The following is a description of a gene set: Mouse Gene Set: MIR_694 studied in species Mus musculus from publication Chen Y, Wang X (PMID 31504780) Genes predicted to be targets of miRBase v22 microRNA mmu_miR_694 in miRDB v6.0 with MirTarget v4 prediction scores > 80 (high confidence targets)., and this is the list of marker genes: St18, Spice1, Nek4, Slc28a2b, Tmem67, Kif1b, Nwd2, Pgm2l1, Sh2d1a, Pik3c2g, Dnmt3b, Ect2, Clic5, Cd2ap, Rhobtb3, B3galt2 (NCBI Gene Id 26878), Ttpa, Gria2, Zdhhc21, Chp1, Vps37a, B230219D22Rik, Gprc5b, Fmr1, Htr5a, Kdm7a, Tox, Ncoa7, Ap1s2, Cpvl, Man2a1, Wnt3a, Tmem39a, Arih2, Mrgprb1, Pigp, Pik3c2a, Gnpda1, Thsd7a, Grik2, Uba3, Uchl4, Cpeb3, Epha4, Nsd3, Slc31a1, Tmcc2, Naaladl2, Phf6, Dnajb11 (DnaJ heat shock protein family (Hsp40) member B11), Atrx, Spty2d1, Dach2 (NCBI Gene Id 93837), Rwdd4a, Ccdc82, Hamp2, Csk, Golm2, Bbx, Pkp2, Slc30a7, Ints8, Smurf2, Pcdhb21, Nap1l5, Ino80d, Kcnmb1, Slain1, Fndc3c1, Washc4, Bdp1, Ap1g1, Eml6, Msi2, Rsbn1, Ppp1r27, Rbm47, Mxi1, Eefsec, Nfyb, Nrg2, Rabep2, Hook3, Srsf11, Jade3, Ehf, Nipal1, Clic4, Fgfr2, Srsf6, Mospd2, Mfap3l, Rora, Lpar4, Slc28a2, Prdm1, Btbd1, Cd46, Zbtb10, Lsm14a, Pcdh10, Cul3, Hacd2, Zfp462, Clmn, Phf3, Wasl, Prr14l, Taok1, Dnm3, Tbc1d12, Ppp4r2, Hoxb2, Cnbp (cellular nucleic acid binding protein), Paxbp1 (PAX3 and PAX7 binding protein 1), Fmn2, Ano1, Sirpb1b, Adk, Ammecr1, Ccdc141, Saxo2, Kpna4, Bicd1, Hipk1, Pibf1, Ngf, Carmil1, Ska1, Peg10 (NCBI Gene Id 30899), Ggct, Zfp518a, Mfsd14b (major facilitator superfamily domain containing 14B), Aco1, Pgm2, Opcml, Tmx4, Slc10a7, Slc35g1, Ehbp1, Arsk, Gnpnat1, Ano5, Ccdc62, Lhx4, Tmem200a, Rab21, Cpeb2, Itprid2, Cacna2d2, Rchy1, Bmpr2, Gucy2f, Etaa1, Kif18a, Calr3, Nup160, Atf6, R3hdm1, Mat2a, Kcnj12, Cnst, Sowahc, Ugt2a3, Pabpc5, N4bp2l2, Bin3, Rap1b, Akap5, Phactr3, Slitrk2, Gabrg1, Chic2, Miga1, Edil3, Trhde, Cxadr, Tnrc6b, Pxn, Tmed7, Dclk1, Elavl1, Cdh6, Dcun1d3, Afg3l2, Epha7, Mtx3, Galnt18, Xpo7, Elovl6, Ltv1, Rev1, Fam81a, Kpnb1, Osbpl6, Chmp1b, Zfp871, Clec1a, Dazl, Tead1, Zfp711, Plcl1, Osr2, Nsg2, Hamp, Hecw2, Wac, Erp44, 2610528J11Rik, Alg5, Mdfic, Fzd3, Pakap, Cxxc4, Rprd1a, Il7, Rimklb, Asxl3, Cldn34b2, Psip1, Plagl2, Cyp2c38, Yap1, Gadd45a, Txnip, Flii, Apool, Mbtps1, Kcnh5, Socs4, Zkscan2, Cyp39a1, Leprotl1, Setd5, A830018L16Rik, Ppp1r2, Ptchd4, Stau1, Pcdh20, Ptger4, Lin7c, Bpnt2, Ube2a, Alkal2, Tmem168, Braf, Klf12, Cggbp1, Trub1, Akr1c14, Clock, Smad2, Sp3, Asxl2, Nexmif, Laptm4a, Pafah1b2, Slc1a3, Rerg, Mindy2, Ddx3y, Slc7a11, Becn1, Slc30a4 (solute carrier family 30 (zinc transporter), member 4), Sgms1, Phlda2, Tnfrsf21 (NCBI Gene Id 98092), Tmem263, Negr1, Ces5a, Crispld1, Bag2, Lca5, Map3k1, Gosr1, Pou3f3, Dsc1, Prrg1, Ubxn2a, Kansl1, Tlr8, Mospd1, Abce1, Zmat3, Tesk2, Pcsk6, Dcx, Lpar6, Fut9, Cdc73, Zdhhc24, Acadsb, Lnpk, Asph, Foxk1, Zfp781a, Ptprb, Pate12, Cdk12 (cyclin dependent kinase 12), Marchf5, Tet1, Steap4, Ing5, Ano3, Tmtc3, Elavl2, Sanbr, Paqr8, Oxsr1, Dnmt3a, Gcc2, Esrrg, Apbb2, Capn7, Gm15881, Kpna3, Lamtor2, Chl1, Bnc1, Mgat4a, Glis3, Zbtb41, Radx, Arhgap6, Slc7a14, Txlng, Tll1, Pgr15l, Dmc1, Rapgef6, Unc5c, Aff4, Crybg1, Lhx9, Kmt5b, Nme7, Enox1, Dner, Shtn1, N4bp2, Ppp1r1c, Pou3f4, Zfp934, Zfp830, Dars1, Mtpap, Dpp8, Ccdc117, Efcab5, Appl1, Chrdl1 (chordin-like 1), Dennd6a, Slc8a1, Nhsl1, Sec24a, Rad23b (NCBI Gene Id 78352), Pyurf, Ypel2, Spred1, Galnt13, Pclaf, Tph2, Rasef, Ces2g, Ebf1, Csnk1g3, Arih1, Sertad4, Slc39a8, Bptf, Hdx, Dzip3, Zmynd11, Pde10a, Son, Ttc14, Thoc2 (THO complex 2), Tmem59, Rbm25, Zfp704, Rheb, Tubd1, Tubgcp3, Pgbd5, Prkd1, Pcnx1, Snrnp48, Pfkfb2, Whrn, Kdm8, Uri1, Phf14 (NCBI Gene Id 76289), Stap1, Mtmr11, Kank1, Hsd17b7, Lrch1, Fst, Fcsk, Mef2c, Vcan, Rnf138, Rbak, Ptprg, Plscr1, Map2, Pld6, Glce, Nufip2, Mphosph9, Picalm, Scn8a, Skida1, Vcpip1, Vstm2a, Ppp2r5e, Esco1, Abi3bp, Pnisr, Klhl23, Eddm13, Exo1, F2r, Il1rap, Bdnf, Cldn34b4, Sox2, Grm5, Hsd17b4, Xk, Rel, Uchl3, Ptchd1, Insm1, Suox, Ankmy2, Pou2af1, Zc3h6, Slc38a2, Ccser1, Zbtb44, Cldn1, Pfdn4, Pianp, Cldn34b1, Larp4, Pitpnb, Cltc, Uba2, Kcnj13 (NCBI Gene Id 100045137), Eml5, Chic1, Mgat1, Nphp1, Ccn4, Gab2, Ranbp3l, Smg1, Nab1, Zeb2, Lman2, Cbx5, Runx2, Arl6, Fat3, Vangl2, Kdr (kinase insert domain protein receptor), Akap17b, Nova1, Raph1, Crls1, Slc35c1, Chm, Tmprss11g, Dmxl1, Rag1, Cnot6l, Setd3, Or51e2, Txlnb, Rps6ka5, Tm7sf3, Zdhhc13, Nphs1, Arnt2, Gls, Vwc2, Wdr26, Donson, Chchd1, Cep135, Zdhhc20, Mtmr10, Snx7, Vmn2r81, Cep290, Ddx60, Cdk8, Hexim1, Cadm2, Cep97, Magi2, Ssx2ip, Ttc39b, Mbnl1, Hectd2, Amot, Sclt1, Nsmce2, Ywhaz, Tspoap1, Pcsk2, Rims2, Rbm6, Ssbp3 (NCBI Gene Id 72475), Fbxl5, Tmem106b, Glo1, Purb, Ppm1k, Slc4a10, Pitrm1, Cdv3, Qser1, Rictor, Tent4b, Polk (NCBI Gene Id 27015), Ramac, Kctd9, Catsperg2, Fnip1, Aebp2, Lgalsl, Rev3l, Gdpd1, Pou2af3, Tmem167, Slc22a3, Jazf1, Lmbr1, Eif2s3y (NCBI Gene Id 26908), Col19a1, Spesp1, Csmd3 (NCBI Gene Id 74943), Cdc6, Zfp9, Trio, Matr3, Cdk2ap1, Flg2, Serpinb7, Ubtd2, Serbp1, Lrrc42, Dsel, Zfp521, Mgat2, Gpr22, Nsd2, Mypop, Ro60 (NCBI Gene Id 98411), Ubxn7, Pcdh9 (NCBI Gene Id 68959), Slc35f5, Ppp1r21, Ncoa2, Wdr47 (NCBI Gene Id 99512), Lztfl1, Nsrp1, Rfx7, Cyp7a1, Cux1, Tsc22d2, Iqub (NCBI Gene Id 214704), Nrg3, Kcna1, Mdga2, Slf2, Pgap1, Prrx1, Slco6c1, Castor1, Hdac2, Svip, Fgf14, Chek1, Fnbp1l, Kalrn, Hipk3, Baz1a, Ttc9, Eif2s3x, Pias1, Dppa1, Tbc1d8b, Elp4 (elongator acetyltransferase complex subunit 4), Rab9b, Senp7, Tpbg, Nup153, Cmpk1 (cytidine/uridine monophosphate kinase 1), Pdxk, Tiam2, Cdyl2, Slc41a1, Crebrf, Lrch3, Sav1, Vps26a, Arhgef6, Large2, Slk, B4galt6, Sirpb1c, Smagp, Pate6, Zbtb33, Epb41, Plaa, Srebf1, Papola, Ralgps1, Slc35a5, Spinkl, Mier3, Ramacl, Iqsec1, Tex30, Osbpl11, Spcs2, Mblac2